The following is a description of a gene set: The chemical reactions and pathways resulting in the formation of dolichol-linked oligosaccharide, usually by a stepwise addition of glycosyl chains to endoplasmic reticulum membrane-bound dolichol-P. studied in species Homo sapiens Human Gene Set: GOBP_DOLICHOL_LINKED_OLIGOSACCHARIDE_BIOSYNTHETIC_PROCESS, and this is the list of marker genes: ALG11, ALG5, ALG1, MPDU1, SRD5A3 (steroid 5 alpha-reductase 3), ALG9, ALG8, ALG13, ALG10, DPM1, DHDDS, DPAGT1, DOLPP1, ALG12, ALG2, DOLK, ALG3, ALG10B (ALG10 alpha-1,2-glucosyltransferase B), ALG14, NUS1, ALG6, RFT1